The following is a description of a gene set: studied in species Mus musculus The chemical reactions and pathways involving acyl-CoA, any derivative of coenzyme A in which the sulfhydryl group is in thiolester linkage with an acyl group. Mouse Gene Set: GOBP_ACYL_COA_METABOLIC_PROCESS, and this is the list of marker genes: Pgk1, Acsm3, Abcd1, Pdhx, Hsd17b4, Acsm5, Acot10, Pdha1, Gpam, Suclg2, Acot2, Mmaa, Acss2, Mpc2, Vdac1, Hmgcs1, Nudt8, Ehhadh, Elovl7, Nudt7, Bckdk, Pipox (NCBI Gene Id 19193), Mvk, Slc27a3, Acsm4 (NCBI Gene Id 233801), Gpat4, Oxct2a, Far2, Acnat1, Acaca, Elovl4, Mvd, Pdk2, Pdhb (pyruvate dehydrogenase (lipoamide) beta), Aadat, Acss1, Ppcs, Tdo2, Ces1d, Acly, Acacb, Elovl1, Acot4, Pdk1, Kynu, Acot5, Acadsb, Acsm1, Acot3, Dlst, Dld, Dip2a, Fasn, Gcdh, Ogdh (oxoglutarate (alpha-ketoglutarate) dehydrogenase (lipoamide)), Pdha2, Elovl5, Far1, Oxsm, Aass, Dgat1, Acot8, Hmgcs2, Acot7, Dlat, Sucla2, Them5, Elovl6, Acaa2, Tpk1, Mmut, Csl, Acot12, Acot9, Acat1, Mpc1, Acsl3, Nudt19, Elovl3, Hmgcl, Pmvk, Acsl6, Baat, Acot6, Acsl1, Pdk3, Mlycd, Acsl5, Acsl4, Acot1, Mcee, Cs, Hnf4a, Suclg1, Acnat2 (acyl-coenzyme A amino acid N-acyltransferase 2), Acsm2, Acot11, Glyat, Dgat2, Fitm2, Snca, Pdk4 (NCBI Gene Id 27273)